The following is a description of a gene set: Human Gene Set: REACTOME_MITOTIC_METAPHASE_AND_ANAPHASE species: Homo sapiens Mitotic Metaphase and Anaphase, and this is the list of marker genes: CLASP2, ANAPC11, CENPH, MIS12, TUBB2B, CENPI, CENPE, CDCA5, NUP188, SKA2, CHMP4B, SPDL1 (NCBI Gene Id 54908), AURKB, TUBB6, CHMP4A, NSL1, PSMD2, UBB, PDS5A, PPP2R5D (NCBI Gene Id 5528), ZW10 (zw10 kinetochore protein), DYNC1LI2, TUBB4A, IST1, CHMP2A, KNL1, UBE2C, PSMA5, POM121, PPP2CA, PPP2R5B, DYNLL2, CHMP7, PSMD6, CDC16, SIRT2, ZWINT, DYNC1I2, DYNC1I1 (dynein cytoplasmic 1 intermediate chain 1), PAFAH1B1, SPAST, PSMB4, PSMD11, PSMB3, PSMC4, CDC20, TUBB2A, DSN1, CENPL, CENPK, NUP62, PSMC6, XPO1 (exportin 1), CCNB1 (cyclin B1), BIRC5, SKA1, ANAPC16, ANAPC10, DYNC1LI1, ADRM1, TUBA3E, KPNB1, CENPP, SEH1L, STAG1, TUBB3, PPP2R5A, TUBA8, ESPL1, STAG2, ERCC6L, NDEL1, CENPT, TUBA4A, RANGAP1, CHMP4C, PSMB2, PMF1, ANAPC4, PSMA1, TMPO, ANAPC7, MAPRE1, NUP35 (NCBI Gene Id 129401), PSMB5, PSMA2, NUP155, PPP2R1A, CENPU, CLIP1, BUB1B, MAD2L1, NUDC, PSMA4, PSMC3, CHMP6, ANAPC15, VRK2, WAPL, TUBB8B, UBA52, CKAP5, CLASP1, CDK1, CHMP3, TUBAL3, NUP85, TUBB1, SPC25, PPP1CC, SMC3, RPS27A, RPS27, CDC27, LEMD2, PPP2R1B, NUP160, LBR, UBE2I, FBXO5, CENPN, TUBA1A, DYNC1H1, PPP2CB, LMNB1, SGO1, PTTG1, KIF2C, PSMD13, NUP107, ZWILCH, NUP58, UBE2S, ANAPC1, CHMP2B, CENPA, TUBA1B, ANAPC5 (NCBI Gene Id 51433), KIF2B, NUP43 (nucleoporin 43), ANKLE2, BUB3, PSMB1, NUP37, TUBA4B, SPC24 (SPC24 component of NDC80 kinetochore complex), KIF2A, SMC1A, PSMC2, EMD (NCBI Gene Id 2010), TUBB4B, PSMB7, ITGB3BP, BUB1, PSMA7, PLK1, PSMB6, KNTC1, UBC, PSMD8, SEM1, CENPF, AHCTF1, NUP93, LEMD3, CENPC, NUP133, PSMD1, PSMC5, SGO2, NDE1, SEC13, PSMD7, TUBB8, ANAPC2, NUP54, B9D2, RAD21, VPS4A, HDAC8, INCENP, CDC26, SUMO1 (small ubiquitin like modifier 1), TUBA1C, DYNLL1, PPP2R5C, PSMA3, CENPS, PSMA6, PPP2R5E, NUF2, RANBP2, VRK1, PSMD3, NDC80, TNPO1 (transportin 1), RCC2, CENPO, RAN, UBE2E1, RCC1, CDCA8, CENPQ, PDS5B, BANF1, MAD1L1, TAOK1, NUP205, PSMD12, CENPM, PPP2R2A, CC2D1B, NUP98, CCNB2, TUBA3C, TUBA3D, KIF18A, NDC1, CDC23, PSMD14, LMNA, UBE2D1, PSMC1